The following is a description of a gene set: Mouse Gene Set: GOBP_REGULATION_OF_VASCULOGENESIS studied in species Mus musculus Any process that modulates the frequency, rate or extent of vasculogenesis., and this is the list of marker genes: Kdr, Rap1a, Ramp2, Asb4, Rtn4, Emp2, Ceacam1, Tmem100, Hey2, Adm, Cd34, Xdh, Rras, Rin2, Hey1, Rapgef2